The following is a description of a gene set: Human Gene Set: GOMF_AP_1_ADAPTOR_COMPLEX_BINDING species: Homo sapiens Binding to an AP-1 adaptor complex. The AP-1 adaptor complex is a heterotetrameric AP-type membrane coat adaptor complex that consists of beta1, gamma, mu1 and sigma1 subunits and links clathrin to the membrane surface of a vesicle. In at least humans, the AP-1 complex can be heterogeneric due to the existence of multiple subunit isoforms encoded by different genes (gamma1 and gamma2, mu1A and mu1B, and sigma1A, sigma1B and sigma1C)., and this is the list of marker genes: RAB32, RAB38, AP1AR, LDLRAP1, SIDT2